Given this list of marker genes Gng5, Kcnj15, Kcnj6, Kcnj1, Kcnj10, Gng11, Gnb2, Kcnj3, Kcnj5, Gnb1, Gngt1, Kcnj4, Abcc8, Gng12, Kcnj8, Gng10, Gngt2, Gabbr1, Gabbr2 (gamma-aminobutyric acid type B receptor subunit 2), Kcnj12, Gng13, Gng8, Gnb4, Gng2, Kcnj2, Kcnj16, Kcnj11, Gng7, Kcnj14, Gng4, Kcnj9, Gnb3, Gng3, Gnb5 (NCBI Gene Id 14697), Abcc9 (NCBI Gene Id 58900), here is a description of the gene set: studied in species Mus musculus Mouse Gene Set: REACTOME_INWARDLY_RECTIFYING_K_CHANNELS Inwardly rectifying K+ channels